The following is a description of a gene set: studied in species Homo sapiens Human Gene Set: MODULE_201 Genes in the cancer module 201., and this is the list of marker genes: PLN, ACTN3, C4B, ALDOA, PRKG1, MYL1, NEB, MYL7, FKBP1B, NOS1, MYL11, SCN5A, SCN7A, BDKRB2, FLII, MYOM1, RYR1, TNNT3, CACNG1, KCNMB1, KCNA1, CRYAB, MYH3, EDNRA, ACTC1, CHRNB1, CNN3, MYH7, CKMT2, TNNI2, MYL3, PPP1R12B, ACTA1, MYH11, ROCK2, VIPR1, CALD1, GJA5, MYOM2, GNAO1, FXYD1, MYBPC1, MYBPC2, SSPN, HRC, CASQ2, KCNH2, OXTR, PPP1R12A, GJA1